Given this list of marker genes Clcn7, Slc26a8, Glrb, Slc4a9, Ano7 (NCBI Gene Id 404545), Clca2, Clca3a1, Slc26a6, Clcn4, Bsnd (NCBI Gene Id 269570), Stx1a (NCBI Gene Id 20907), Slc26a10, Ano8, Clcn5 (NCBI Gene Id 97624), Tmc4, Clic6, Clca3a2, Gabrg1, Gabrr2, Clca4b, Slc26a9 (solute carrier family 26, member 9), Slc26a11, Best1, Ano2, Gabra2, Slc26a4, Clcc1, Nmur2, Slc26a2, Clcnkb, Slc4a3, Slc6a13, Gabra5, Clcn1, Gabrb1, Stx7 (syntaxin 7), Aqp6, Slc25a27, Ttyh3, Slc17a6, Pacc1, Slc18a1, Gabra3, Ano3, Slc6a4, Gabrr1, Clca3b, Slc1a1, Vamp8, Gabrb2, Slc12a3, Best3, Clcn6, Slc18a2, Slc1a4, Slc12a7, Slc12a4, Slc17a7, Glra3, Gabre, Cldn17, Slc12a8, Apol10b, Chrm5 (cholinergic receptor, muscarinic 5), Slc26a7, Apol8, Gabrg2, Trpv1, Vti1b, Apol9b, Slc6a3, Clcn3, Slc12a5, Glra4, Apol9a, Clcnka (NCBI Gene Id 97123), Ano1, Gabrp, Slc26a5, Best2, Gabrg3, Slc4a1, Slc4a2, Cftr, Slc6a18, Slc22a1, Chrna7, Slc1a7, Slc12a6, Slc12a9, Slc6a11, Stx8, Ano4, Ttyh1, Clca4a, Slc12a1, Slc4a8, Slc17a8, Glra1, Gabrq, Gabrd, Apol10a, Gabrr3, Apol11b, Slc6a8, Ano5, Cldn4, Slc22a3, Ttyh2, Ano6, Mfsd8, Ucp2, Oca2, Slc26a3, Nherf1, Slc26a1, Clcn2, Slc4a10, Gabra4, Slc12a2, Ano10, Slc6a6, Gabra1, Gabrb3, Clic3, Gabra6, Clic1, Apol11a, Slc6a2, Slc25a14, Slc6a1, Clic4, Clic5, Ano9, Slc6a12, Glra2, Clca1, here is a description of the gene set: Enables the transfer of chloride ions from one side of a membrane to the other. species: Mus musculus Mouse Gene Set: GOMF_CHLORIDE_TRANSMEMBRANE_TRANSPORTER_ACTIVITY